The following is a description of a gene set: Genes predicted to be targets of miRBase v22 microRNA hsa-miR-616-5p in miRDB v6.0 with MirTarget v4 prediction scores > 80 (high confidence targets). studied in species Homo sapiens from publication Chen Y, Wang X (PMID 31504780) Human Gene Set: MIR616_5P, and this is the list of marker genes: KRBOX4, RPL15, SGCB, TLCD2, TXNIP, WHAMM, SKA2, NUDT19, HMGN2, SLC25A32, PCDHB11, ZCCHC4, MPV17L, CHSY3, NEPRO, RRM2, SNAPC3, ELAVL2, RRP15, G6PC1, ZCCHC8, ATP13A4, LONRF2 (NCBI Gene Id 164832), LYRM7, ZNF578, C2orf69, ATXN7, PPM1A, NPIPB13 (nuclear pore complex interacting protein family, member B13), ST6GAL2, SHOC2, EEF1A1, ADAMDEC1, ZNF101, ATP1B4, C19orf12, LSM8 (LSM8 homolog, U6 small nuclear RNA associated), DBT, ZNF765, SULT1C4, LRPAP1, ZCCHC24, ZNF845, ARGFX, AS3MT, RBL1, CALCB, GOSR2, ARFIP1 (NCBI Gene Id 27236), FDFT1, ARHGAP5, DAND5, TMF1, DCP2 (NCBI Gene Id 167227), DENND1B, INMT, TRAPPC2, AIFM2, FGD5, CBX5, ZNF816, SKA1, SYT15, MCTS1 (MCTS1 re-initiation and release factor), PLA1A, HECA, OPRK1, UPK3BL1, ZNF286B, EEA1, OGFRL1, WAC, CCNT2, FBXO28, TPMT, NPAP1, ZNF805, ATXN3, FAM217B, ZNF281, GSPT2, SCAMP1, RPP30, CDCA7L, SLC2A4, CYP4F3, AIG1, SMC1A, CLSPN, SVBP, ELK4, ANO6, MTHFD2L, MFSD4A, UTP25, PDP2, CFAP210, INSYN1, ACTR2, SAR1B, ADAMTS18, SUPT7L, TMX1, TAS2R20, SLAIN1, TMEM41B, SERF1A, TLCD4, C15orf40, SPATS2L, ATRX, LRRC28, LETM1, CPSF2, CCDC122, PRKCI, PHLDA1, XPNPEP3, NUFIP2, PDZD8, AUNIP, IFNAR2, TANGO2, KCTD14, METTL8, HPS3, FZD3, ZSWIM1, PSTPIP2, RAP1A, GPANK1, ZNF816-ZNF321P, BBIP1, SV2B, BPNT2 (NCBI Gene Id 54928), SINHCAF, CILK1, SIGLEC14, UHMK1, MTFMT, CEBPZOS, JAK3, LILRA5, COX6B2, EPB41L4A, SS18, KRIT1, MRPS11, ZNF611, RBMS3, BLNK (NCBI Gene Id 29760), IRGQ, CA5B (NCBI Gene Id 11238), ZNF286A, ALS2, IGF2BP3, FYB2, GSR, PDK3, NCBP3, PCDH10, RAD51AP2, SLC16A4, SMU1, MEFV, VHL, CYP51A1, P2RY1, PIK3CA, GABPA, PCBD2, ISL1, EFR3B, DCAF17, ZNF808, ZDBF2, HACD2, CSK, HMBOX1, CENPA, RMDN1, CA8, USP33, WNK3 (WNK lysine deficient protein kinase 3), MAVS, NLRC3, AKR1D1, UBE2K, GCSAML (germinal center associated signaling and motility like), SHCBP1, IFI6, SUMF2, PRR27, PTGES3L, LINC02897, INPP5B, PPP4C, CRIPT, ME2, ELF5, PRELID2, LRPPRC, SLC9A7, CASTOR2 (cytosolic arginine sensor for mTORC1 subunit 2), OLFML1, SDHA, PGR, FGD2, OLFML2A, SLC4A8, GPR37L1, ACKR2, SNX1, HUS1, TMEM52B, NUGGC, COX18, SGPL1, POU2F3, UBE2W, ORAI3, FAM111A, ZNF326, ZNHIT6, RIMKLB, MGAT4A, FGD4, STRIP2, ARSB, ZFC3H1, CDH6, RSKR, MOB1A, STX11, WDR87, LATS1, ZNF839, KL, APOBEC3D, FRG2C, IYD, PHF20L1, KMT5B, HEG1, CEP97 (NCBI Gene Id 79598), C2orf68, MLANA, FGFBP3, SENP5, ZNF736, ELOVL5, MFSD14B, PAPOLG (NCBI Gene Id 64895), MRPS30, TOP3A, SLC17A3, HTR1D, PLAC8, ZNF780B, MTRR, TGFBR1, ZBTB2, TIMM10B, ARMCX3, NOL9, HPSE, ZNF7, MCM4, CRTAP, FBXW2, HOGA1, OR2H1, GPI, FAM114A1, MIA3, TOGARAM1, SATB2, MLEC, SYNPO2, FEZ1, SMIM17, FBXL17, SART3, STEEP1, SPC24, SLC10A7, CCSER2, CSGALNACT2, TRIM13, SFR1, FOXL2NB, SLC16A7, MYO3B, NEK2, SERPINB9, SKP2, CNOT6L, POLR1G, RASGRP4, SLC41A2, ARCN1 (archain 1), XIAP, PAICS, WDR44 (NCBI Gene Id 54521), UNC80, ZBTB25, SLC15A5, ZNF850, RAD54L2, TAS2R14, POLR2J3, KCNJ14 (potassium inwardly rectifying channel subfamily J member 14), PIP4K2A, VMP1, PLEKHH2, RTCA, RPS24, POLH, POLR2M, APOL2, MPIG6B, PAPLN, PAIP2B, FTO (NCBI Gene Id 79068), SLC35E2A, ADAMTS4, PPFIBP1, ARAP2, EEF1AKMT3, FRG2, TRDN, CHP1, RARS2, KIAA1210, STRADB, USP9X, SLC19A4P, PHTF2, TM4SF20, SERTAD2, C3orf70, KLF5, GEMIN5, TVP23C, TBCB, TMEM106B, TRAF3IP2 (NCBI Gene Id 25997), SNIP1, PLEKHF2, MARVELD2, ATP6V0A2, SLC24A4, SURF4, GPN3 (NCBI Gene Id 95310), MYLK4, ENAH, TNFSF9, FGF14 (fibroblast growth factor 14), SDE2, HIF3A, TOPORS (NCBI Gene Id 641432), CPS1, GM2A, SCD, RAD52, THAP5, BAG5, DBR1, CHMP1B (NCBI Gene Id 57132), INHBE, SPAG9, EIF2S3, PABPC5, ABHD18, APOL6, ST8SIA4, GUCY1A2, MDM1, TCTN2, VCPIP1, RNF8, ATAD5, PDE6B, ARPIN, LSM11, ZNF28, TRA2B, ZNF568, TTN (NCBI Gene Id 7847), SH3BGRL2, CRCP, DISC1, GNG2, TEDDM1, HYKK, QPCTL, RASSF5, WDR76, SLC8A1, FBXO44, CSTF2T, AEBP2, TGS1, JAK2, CEACAM8, SGCD, FAM210A, EXOC5, GTF3C4, TASOR, IPMK, MYO5C, THUMPD2, EPB41, ZNF454, TCF7, PTER, RTKN2, TENM3, FLRT2, ZNF626, CFL2, STEAP4, DIAPH2, LY75, SH3TC2 (NCBI Gene Id 79628), LRRC19, TNS4, FNDC3A, TAPBP, PRTG, SIX4, CSDE1, ALKBH5 (NCBI Gene Id 54890), TMEM167B, MOB3B (MOB kinase activator 3B), PIGR, FAM117B, PWWP3B, ZNF527, ZNF595, PITPNM2, TRIM16, DNAJC14, SLC25A34, SH3D19, ACTR10, MTPAP, ZBTB3, TSNAX, GINS1, GRSF1, CNBD2, FAM20B, SLC12A8, NSL1, ELAPOR1, MYLK3, CCNY, VPS53 (NCBI Gene Id 55275), GNG4, ZMYM1, UBA5, ILDR2, EIF4E, MATR3, VPS26A, MTR, PCDHB16, REEP3, SLC30A5 (NCBI Gene Id 79021), ZNF770, COLCA1, ACOX1, KBTBD6, BCL10, TRPM7, C2orf49, GNS, COMMD8, GCM1, RASGEF1A, DOCK1, APOOL, RIT2, ZNF124, RCN2, SCAI, PDE12, ZNF709 (zinc finger protein 709), LAMP2, CHSY1, SERPINB1, KLLN, ARID5B, ZNF264, ZNF493, DCUN1D1, CEP15, GSDMA, ACYP2, WDR27, PEAK3 (NCBI Gene Id 374872), MBOAT1, SULT1E1, KIF3A (kinesin family member 3A), TRPM6, ATL3, EMC1, TXNDC9, GTPBP3, APOBEC3F, PURB, RBSN, LRRC47, DNAL1, BRIP1, MIER3, SEC63, RHPN2, GNB4, EMP2, LRRC51, KRT222, DTX3L (NCBI Gene Id 151636), ZNF490, CGNL1, OLR1, ALDH16A1, GXYLT1, ZFP14, RLIM, TXNRD2, EPG5, NDRG3, GLB1L3, NLK, NF2, MS4A10, KIF16B, ZC3H12B, CLEC7A, PALS1, LMTK2, C16orf54, MRPS16, RNF115, UTP11, DCUN1D5, TSPYL1, CNBP, SLC13A1, WDR55, PPM1K, UBE2V2, SCN9A, STON1, SVOP, BLOC1S2, KIAA1143, CYP8B1, KPNA3, HECW2, MRI1, UMPS, SDC2, LIX1L (NCBI Gene Id 128077), CREBZF, UTP20, RNF207 (NCBI Gene Id 388591), GPR83, TBC1D7, HELLS, SERBP1, PLEKHA5 (pleckstrin homology domain containing A5), H6PD, CCNJ, CEP72, CIPC, ALG1, KLF8, SIKE1, PTEN, MAPK1IP1L, FRMD8, RBBP4, SOAT1, RAB33B, WDFY1, KIF5C, NIM1K, SCN3B, ZMYM6, TCP11L1, PSMD12, POLR2J2, MED17, FZD2 (NCBI Gene Id 2535), CD3G, FABP7, S1PR5, CYP20A1, ZNF793, TFCP2L1, SLC15A1, ZNF221, GLG1, NCCRP1, CBX6 (chromobox 6), C21orf91, APRG1 (APRG1 tumor suppressor candidate), ZBTB8OS, STAT2 (signal transducer and activator of transcription 2), GRB14, CDX1, IBA57, FSIP1, ZNF543, CREB1, GABRP, EPHA3, SLU7, GRM3, SPIB, PYGO1, SERF1B, HIGD1A, CD274, PNPO, AADAT, RPL34, KRR1, ZFP36L2, FAM204A, THOC3, ZNF100, SLC34A2, PPAT, TERF2, ETFBKMT, TFAP2C, ACACB, SNTB2, TIMM50, S1PR2, ZNF530, STAM, PLAAT5, PI4K2B, STIL, PSPH, TBK1, COX15, STON2, PAFAH1B1, ARF4, BAZ1A, HP1BP3, FGF12, ZSCAN2, UQCC3, SCAF11, RAB21, ZNF587, PIWIL1, CACNA1D, CYP1A2, SALL4, TMEM59, RAB11A, GTF2IRD2B, NDUFA4, IKZF3, VPS33B, VENTX, TMTC1, SSX2IP (SSX family member 2 interacting protein), DICER1, NR5A2 (NCBI Gene Id 8768), SLC48A1, VSIG10, FRZB, SLC24A1, ARL17A, TULP4, NEXMIF, ZNF260, TPM3, ALDH18A1, HAVCR2, ALDH6A1, OR51E2, ADPRH, VIPR2, GSTCD, ZSCAN9, RTBDN, KIN, LZIC, FNBP4, SLC35F6, MRFAP1, TRPV1, PDE7A, CBL, RHD, SERPINB8, DUSP19, SMUG1, FOXK1, FKBP11, ZCCHC14, ARHGAP35, FANCF, CCDC65, TMEM239, NIBAN1, ZNF426, TMED4, TRIM5, IKZF1 (NCBI Gene Id 55429), SPAST, DCUN1D2, NAIF1, TWF1, SMAD4, REPS2, MACO1, KDM1A, KPNA4, MORN4, LPGAT1, MSMO1, ITGAX, AAK1, TOR1AIP2, F3, ANGPT4, PIGW, KLHDC1, ZNF785 (zinc finger protein 785), SLA2, SLC6A11, PIK3CD, HS3ST3B1, OCLN, ZNF699 (zinc finger protein 699), SLC25A45, DHH, TMEM120B, R3HDM2, AP1G1, MDM2, PTGIS, CCDC50, MTX3, E2F2, UBA52, VIP, CYLD, PRR23A, FUS, EDEM1, MBD4, RBM43, CR1, ARL6IP1, NOM1, CAND1, WDR5B, DUSP3, SERPINB13, TRIAP1, SNX13, MAP7D3, GCOM1, SLC36A2, CPA4, TMEM170B, TENT4B, TENM2, FSBP, TRMT9B, SPN, ANKRD17, GNA13, ZSWIM4, FDXACB1, INTS6, RHNO1, MFSD8, SHOX (NCBI Gene Id 6473), ZNF621, ZC3HAV1L (zinc finger CCCH-type containing, antiviral 1 like), SNX22, ABCA5 (ATP binding cassette subfamily A member 5), RAD54B, CHRDL1, TVP23A, CEP70, ICE2, ZNF587B, COLEC10, TAB3, RYR2, SPECC1, ENPP1, ERCC6L2, SYT4, ZNF681 (NCBI Gene Id 148213), RPS27L, TAF8, ZNF600, CRIPTO, KIF18B, MRPL19 (NCBI Gene Id 9801), MGA, DCDC1, ZNF814, RBM8A, GALNT12, C5AR1 (NCBI Gene Id 728), SCIMP, ZNRF3, OSBPL10, CLCC1, PARD6B, STMP1, IRF9, SCARF1, MFAP3L, GNL3L, TRIM59, RLF, PNISR, PDHA1, SIGLEC11, USF3, OSMR, NMNAT1, TMED5, ZNF552, PATJ, AFG2A, APPL1, GAPVD1, NCAPG2, CAMLG, GTF2IRD2, NDUFV3 (NADH:ubiquinone oxidoreductase subunit V3), HOOK3 (hook microtubule tethering protein 3), ZNF451, FOXP2, TIPRL, CCDC141, ADIPOQ, MPC2, CCL16, CEBPB, ZBTB7A, HAUS5, AFMID, AMER2, RETREG3, KALRN, SAMD4A, METTL6, UCK2, ZNF22, TRIM16L, ATF7IP, FXN (NCBI Gene Id 2395), HRH4, GKN2, PHACTR4, FCAR, NHLRC2 (NHL repeat containing 2), MCCC2, FBXL20, CNOT6, CHD6, TIMM23B, RP2, SUSD5, MDM4, TMEM33, TFDP2, SYNJ2BP, DHRSX, NDUFC2, RNF125, GPATCH2L, VPS13C, ZC3HAV1, CREB5, SCML2, SCD5, CASP2, CLDN12, MRO, ACTN4, HDAC2, ALG9, NOCT, GATD1, TMEM184C, ZC3H13, BVES, MS4A2, CISD2, BRD2, CYB5R3, GOLM2, FAM234B, MAST3, MAP4, ASPN, ZNF253 (NCBI Gene Id 56242), SPACA9, SPRYD4, PPP1R15B, SOX4, CD226, RGS9BP, LRP2BP, AP4S1, ZNF486, KLHL30, MAPK8, CACNG4, KHDRBS2, MSS51, TENM4, PURA (purine rich element binding protein A), LURAP1, GOLGA3, STX2, SLC5A5, CNTLN, TXNL4B, LEPROTL1, TRAF3IP1, ZC3H6, ATF1 (NCBI Gene Id 466), CDC5L, FAM228B (NCBI Gene Id 375190), DACT2, ITGB8, NDUFC2-KCTD14, CYP2B6, PTCHD4, ZNF557, TOR1B, ANKS4B, TKT, PCDHB9, MOCS3, DSCAML1, PPM1D, TNFRSF10B, TSPAN2